The following is a description of a gene set: Human Gene Set: HP_REDUCED_SOCIAL_RESPONSIVENESS species: Homo sapiens A reduced ability to participate in the back-and-forth flow of social interaction appropriate to culture and developmental level, which is normally characterized by an influence of the behavior of one person on the behavior of another person. This results in difficulty interacting with others through emotional, physical, or verbal communication. Reduced social responsiveness, and this is the list of marker genes: DNAJC6, TARS1, MED12, LRRK2, CNTNAP2, NF1, SH2B1, ADNP, WARS2, HTRA2, ERCC3, RNF113A, CARS1, SLC6A1, FOXG1, POGZ, SMC1A, NLGN1, SLC6A8, AP2M1, PARK7, PLA2G6, SPTBN1, DLK1, TUBB3, SYNGAP1, SHANK3, GRIN1, PODXL, RTL1, MEG3, MAN2C1, NTNG1, EP300, HERC1, SNRPN, GTF2E2, POLA1, IQSEC2, GTF2H5, OPHN1, MPLKIP, FMR1, UCHL1, PUS3, SYNJ1, LINGO1, CREBBP, CLTC, SNCA (synuclein alpha), AARS1, SCN1A, CDKL5, TET3 (NCBI Gene Id 23298), MBD5, SLC2A1, VPS13C, MECP2, ZMYND11 (NCBI Gene Id 10771), CHD8, NEXMIF, PINK1, GRIK2, GABBR2, CHMP1A, CHD2, TTC19, ALG11, ERCC2, TBR1, PRKN